Given this list of marker genes Zdhhc19, Zdhhc24, Zdhhc14, Gm6993, Zdhhc20, Zdhhc6, Sptlc2, Zdhhc13, Cpt1c, Zdhhc9, Zdhhc4, Zdhhc25, Zdhhc21, Zdhhc2, Cpt1b, Sptlc1, Zdhhc3, Cpt2, Sptssb, Zdhhc22, Zdhhc1, Ykt6, Zdhhc16, Zdhhc8, Zdhhc23, Sptlc3, Cpt1a, Zdhhc5, Lrat, Zdhhc11, Zdhhc17, Zdhhc7, Zdhhc18, Zdhhc15 (NCBI Gene Id 68086), Zdhhc12, Glul, Sptssa, Hhat, here is a description of the gene set: Mouse Gene Set: GOMF_PALMITOYLTRANSFERASE_ACTIVITY studied in species Mus musculus Catalysis of the transfer of a palmitoyl (CH3-14-CO-) group to an acceptor molecule.